The following is a description of a gene set: Recurrent episodes of oral herpes, typically characterized by blisters or ulcers on the gums, lips and/or tongue caused by herpes virus. Human Gene Set: HP_RECURRENT_ORAL_HERPES species: Homo sapiens Recurrent oral herpes, and this is the list of marker genes: ICOSLG, REL, NFKB2, POLD1, FCGR3A, TPP2